Given this list of marker genes PIK3CD, VPS51, AMIGO1, TMEM63A (NCBI Gene Id 9725), MRFAP1L2, FCMR, NEURL4, DNAJA3, ZNF395 (zinc finger protein 395), ZFP37, NPAT, SLC9A3-OT1, SPIN3, SYNJ2, SPEN-AS1, PRKRIP1, NOL11, RAB43, LYPD3, ZNF76, ADSL, FOXO1, EGLN2, HAPLN3, UPF1, EEF1B2, PMPCA, NIPAL3 (NIPA like domain containing 3), ANXA2R, TMEM248, ZNF407-AS1, METTL16, ANKRD36, ARFIP2, THUMPD1, BEX3, ITK, NEMP1, UBXN1, PDE7B-AS1, ZNF212, ZBTB4, IL6ST, SUSD3, STAT5A, CNOT6L, ZNF420, SOX8, DKC1, STAT5B, JADE2 (jade family PHD finger 2), MEGF6, FNBP4, RABEPK, LINS1, GPRASP1, PHF1, SLC25A45, CNST, EDC4, TUBG2, PCYOX1L, RIMKLB, SNX9, PCED1B, MIR4453HG, ZNF204P, STMN3, ZFTRAF1, ECHDC2, PITHD1, EFNA1, LYRM7, TARBP2, TMEM143, BCL11B, ATM, LTBP3, SIGIRR, VPS52, MAN1C1, PHF10, CPSF4, CAMK2G, ZNF470, CAND2, CD6, LINC01089, NPM3, TRAF3IP3, ZRANB1, GRAP, COQ10A, RSBN1, COX7C, TMEM245, PPP2R2D, SELENOW, ZNF510, RIOX1, APBB3, DIDO1, IGIP, SNHG32, ARHGEF18, USP20, TMEM272, SLC39A13, LRRN3, TBRG4, POLR1E, PLEKHB1, MAML2, DNAJB1, NUCB2, IPO4, MORC4, AGMAT, BAG3, BBS2, RLIG1, AK5, ZNF251, EVL, BIN1 (bridging integrator 1), TSPYL4, LCK, PXYLP1, PITRM1, TNK1, XPO6, SCML4, EXOSC2, GALNT12, DANCR (differentiation antagonizing non-protein coding RNA), RPL19, ASXL1, PSMB5, SARDH, EIF2D, IL11RA (NCBI Gene Id 3590), QRICH1, IMMP1L, ZNF331, RETREG1 (NCBI Gene Id 96119), SLC25A23 (NCBI Gene Id 79085), EP400P1, AXIN2, RNFT2, MLLT3 (MLLT3 super elongation complex subunit), PRDX2, PIK3IP1, SCML1, OCIAD2, RPUSD4, NSUN5P2, TSPAN18, ZBTB40, ZNF189, CLK4, SNHG1, GON4L, RCAN3, RPS6KA5, SF3A3, SNPH, LAS1L, MTERF4 (NCBI Gene Id 130916), CLPP, ZCCHC14, SUPT20H, CAMK4, LEPROTL1, MAD1L1, ZNF407, LIX1L, PDCD4-AS1, EPHA1, MAFK, CHD3, ZNF32, ABLIM1, ZNF862, NOG, PLAG1, C12orf57, RGCC, GPA33, IGSF8, ZNF575, AMIGO2, IPCEF1, NET1, ZNF275, NSMCE4A, TECPR1, CD27, RPUSD2, here is a description of the gene set: Microarray deconvolution is a technique for quantifying the relative abundance of constituent cells in a mixture based on that mixture's microarray signature and the signatures of the purified constituents. It has been applied to yeast and other systems but not to blood samples. Here we test the ability of this technique to determine the fractions of subsets of memory T cells in peripheral blood mononuclear cell (PBMC) samples. species: Homo sapiens from publication Abbas AR, Wolslegel K, Seshasayee D, Modrusan Z, Clark HF (PMID 19568420) Human Gene Set: GSE11057_NAIVE_CD4_VS_PBMC_CD4_TCELL_UP Genes up-regulated in comparison of naive T cells versus peripheral blood mononuclear cells (PBMC).